The following is a description of a gene set: studied in species Homo sapiens from publication Honma K, Iwao-Koizumi K, Takeshita F, Yamamoto Y, Yoshida T, Nishio K, Nagahara S, Kato K, Ochiya T (PMID 18724378) Genes up-regulated in MCF7-ADR cell line (breast cancer) resistant to docetaxel. Drug resistance acquired by cancer cells has led to treatment failure. To understand the regulatory network underlying docetaxel resistance in breast cancer cells and to identify molecular targets for therapy, we tested small interfering RNAs (siRNAs) against genes whose expression was elevated in human nonresponders to docetaxel for the ability to promote apoptosis of docetaxel-resistant human breast cancer cells (MCF7-ADR cells). The results indicate that the downregulation of the gene encoding ribophorin II (RPN2), which is part of an N-oligosaccharyl transferase complex, most efficiently induces apoptosis of MCF7-ADR cells in the presence of docetaxel. RPN2 silencing induced reduced glycosylation of the P-glycoprotein, as well as decreased membrane localization, thereby sensitizing MCF7-ADR cells to docetaxel. Moreover, in vivo delivery of siRNA specific for RPN2 markedly reduced tumor growth in two types of models for drug resistance. Thus, RPN2 silencing makes cancer cells hypersensitive response to docetaxel, and RPN2 might be a new target for RNA interference-based therapeutics against drug resistance. Human Gene Set: HONMA_DOCETAXEL_RESISTANCE, and this is the list of marker genes: PPP1R14B, PDCD5, ENO1, MRPL17, GAPDH, SLC25A3, APRT, RACK1, ZKSCAN8, ANGPTL2 (angiopoietin like 2), MX1, HSPA5, FXR1, COX7C, CALR, ATP5F1E, MRPS6, NDUFS3, MYDGF, RPL38, RPN2, HACD2, CFL1 (cofilin 1), CLPTM1L, CTNNB1, GSTP1 (glutathione S-transferase pi 1), S100A10, TUBA1B, MAD2L2, DYNLL1, UFM1, IFI6, TUBB, SQOR, ANAPC7